Given this list of marker genes AOX1 (NCBI Gene Id 316), FMO3, UGT1A4, CYP2B6, UGT1A9, CYP2A6 (NCBI Gene Id 82212), here is a description of the gene set: species: Homo sapiens Nicotine metabolism in liver cells Human Gene Set: WP_NICOTINE_METABOLISM_IN_LIVER_CELLS